The following is a description of a gene set: studied in species Homo sapiens Human Gene Set: GOBP_NEGATIVE_T_CELL_SELECTION The process of elimination of immature T cells which react strongly with self-antigens., and this is the list of marker genes: SHH (NCBI Gene Id 6469), THEMIS, CD28, DOCK2, SPN, CD74, PTPRC, CD3E, ATG5, CCR7, AIRE, GLI3, ZAP70